Given this list of marker genes Pabpc1, Hspa1b, Psmc2, Psma4, Psmc3, Psmd12, Psmd1, Hnrnpd, Psma3, Psma6, Psma7, Psmb6, Uba52, Psmc1, Psmd11, Psmb7, Psmc4, Psmd7, Hspa1a, Psmd14 (NCBI Gene Id 98839), Adrm1, Psmb3, Psmc6, Psma1, Psmd3, Ubc, Psmb2, Psmd8 (NCBI Gene Id 99154), Ubb, Hspa8, Psmb5, Eif4g1, Psmb1, Hspb1, Psma2, Uba52rt, Psmc5, Psmd2, Psmb4, Psma5, Psmd13, Rps27a, Psmd6, here is a description of the gene set: Mouse Gene Set: REACTOME_AUF1_HNRNP_D0_BINDS_AND_DESTABILIZES_MRNA species: Mus musculus AUF1 (hnRNP D0) binds and destabilizes mRNA